The following is a description of a gene set: Megacolon Human Gene Set: HP_MEGACOLON studied in species Homo sapiens Persistent and substantial increase in diameter diameter and length of the colon., and this is the list of marker genes: LZTFL1, LBX1, HIRA, SNAI2, ERCC4, SF3B4, CEP104, PIGY, APC2, PDE6D, B9D1, CCDC28B, ARX, SLC6A8, MKKS, KIAA0586, BBS12, PALB2, INPP5E, SETBP1, CSPP1, SUFU, EDNRB, ECE1, PAX3, BCOR, SEMA3D, TCTN2, DDX3X, GDNF, PIGV, IFT74, ERBB3, MITF (NCBI Gene Id 7487), PIGN, TCF4, SH2B1, TMEM231, TCTN1, ARL13B, CEP290, NSD1, FANCD2, UFD1, FANCM, KRAS, TYR, SLX4, KIAA0753, AHI1, MAD2L2, BRCA1, CEP19, PIGW, SOX10, FANCG (FA complementation group G), ASCL1, PIBF1, MYO1H, KIFBP, KITLG, ZNF423, SCLT1 (sodium channel and clathrin linker 1), PGAP2, BBS4, BBS5 (Bardet-Biedl syndrome 5), TRIM32, NAA10, TMEM216, PGAP3, TMEM237, FANCL, BBS2, SEMA3C, MKS1, SEC24C, ZEB2 (zinc finger E-box binding homeobox 2), GP1BB, ABCD1, ATRX, FANCA, SALL4, ARL3, TBX1, FOXF1, FANCI, TMEM67, ACTG2, COMT, TUBA1A, RET, CC2D2A, NRTN, EDN3, CEP41, DHCR7, XRCC2, SDCCAG8, SREBF1, TOGARAM1, FANCB, FANCE, PIGO, TMEM138, ARL6, FANCF, WDPCP, ATP7A, ARVCF, FANCC, KIT, BRCA2, CBY1, ARMC9, BRIP1, BBIP1, OFD1, CEP120, MBTPS2, B9D2, ERBB2, JMJD1C, HYLS1, PHOX2B (NCBI Gene Id 8929), TMEM218 (NCBI Gene Id 219854), IFT27, BBS10 (Bardet-Biedl syndrome 10), KATNIP, RREB1, IFT172, RAD51, UBE2T, SMO, CFAP418, RMRP, PIGL, TCTN3, RAD51C, BBS1, DDX59, NPHP1, BDNF, L1CAM, BBS7, RFWD3, RPGRIP1L, CPLANE1, BBS9, TTC8, SCAPER